Given this list of marker genes TERF2, SEMA6A, MPV17L, SLC6A1, PHF8, ATF2, ZNF426, ZNF148, ZDHHC21, H2BC21, TRIM67, PNMA8B, ATCAY, ITGBL1, MGAT5B, TTC39C, TRIM29, RTKN2, UAP1L1, BTN3A1, ARMCX6, ZNF587, IRF2BP1, HIC2, MS4A10, TNK2, CIAPIN1, GSG1L, ACACB, PRRT1, FBXO41, SYN1, SP6, SMG6, KCNK17 (NCBI Gene Id 90081), ZDHHC22, SMURF1 (SMAD specific E3 ubiquitin protein ligase 1), SMCP, ELMO1, LINC02694, TRA2A, OPCML, KDM5C, SOD3, ZNF490 (zinc finger protein 490), EDA, SAP130, SCRN3, POU2F3, AK2, CALN1, S100A4, SNX27, PLEKHG4B, C2orf68, CCDC150, TTYH3, FOXJ2, ZNF503, ATP2B2, EBF1 (EBF transcription factor 1), IL17RD, ZNF827, FGF5, SLC24A3, ISCA1, KLK10, TNRC6C, CMTR1, GRB2, FRAT2, CHAD, PAQR4, TMEM161B, FGF12, APPL2, RIMS4, SYNPO2L, ITFG2, TMEM178B, ERGIC1, IQSEC2, ARHGAP1, PREP, ENTPD2, PLBD2, CACNA1E, SHC1, MEF2D, MAPK6, CPS1, SYT15, MTHFR, FHIT, VWDE, CTNNA3, here is a description of the gene set: species: Homo sapiens Human Gene Set: MIR6745 from publication Chen Y, Wang X (PMID 31504780) Genes predicted to be targets of miRBase v22 microRNA hsa-miR-6745 in miRDB v6.0 with MirTarget v4 prediction scores > 80 (high confidence targets).